Given this list of marker genes HSD11B1, CYP11B1, CYP11B2, H6PD, CYP11A1, CYP17A1, CYB5A, SRD5A2, POR, CYP19A1, CYP21A2, STAR, HSD3B2, HSD17B3, HSD3B1, HSD11B2, here is a description of the gene set: Classical pathway of steroidogenesis with glucocorticoid and mineralocorticoid metabolism studied in species Homo sapiens Human Gene Set: WP_CLASSICAL_PATHWAY_OF_STEROIDOGENESIS_WITH_GLUCOCORTICOID_AND_MINERALOCORTICOID_METABOLISM